The following is a description of a gene set: Prolonged bleeding following procedure Human Gene Set: HP_PROLONGED_BLEEDING_FOLLOWING_PROCEDURE Prolonged or protracted bleeding following an invasive procedure or intervention. species: Homo sapiens, and this is the list of marker genes: F11, TPM4, RBM8A, APOLD1, F8, ITGB3, F13A1, VWF, IKZF5, FGG, DTNBP1, SERPINE1, F2, GFI1B, DIAPH1, RASGRP2, SLC37A4, F5, GP1BA (NCBI Gene Id 2811), ITGA2B, KIF23, GP9, F13B, RACGAP1, P2RY12, F7, FGA, LMAN1, GP1BB, MCFD2, F10, FGB